Given this list of marker genes Slc23a2, Cadm3, Rab31, Strbp, Pex5, Sdhaf4, Maml2, Tdrd3 (tudor domain containing 3), Slc6a15, Wfdc12, Klf15, Araf, Foxf1, Egr3, Ccdc62, Dgkq, Acvr1, Zmym5, Prr3, Soat1, Dact1, Pard3 (par-3 family cell polarity regulator), Pik3r1, Sytl4, Klc1, Gli3, Prkaa2, Atp1b3, Rnf6, Kdm7a, Cntln, Epg5, Adat2, Mbnl3, Fut9, Cacna2d2, Arid2, Nckap1, Lrp2bp, Adamts20, Bcl9, Ssh2, Bcl6, Dlgap4, Tbx5, Nr2c2, Cdk6, Diaph2, Nif3l1, Tns3, Trip12, Il22ra1, Rabgap1, Suclg1, Rnf217, Ugt2b35, Rnf19b, Snrk, Zfp711, Erg28, Slc16a10, Slc25a27, Nufip2, Zfp811, Ebf2, Srgap2, Slc15a1, Zfp839, Or7d10, Cep70, Dhx40, Rab1a, Gpr4 (NCBI Gene Id 319197), Lmx1a, Eri1, Denr, Slf2, Epha4, Vapa, Tmem178b, Pfkfb2, Gabrb2, Efemp1, Ccna2, Poglut1, Adam2, Herc2, Ndufs2, Zdbf2, Phf21a, Rasgrp1, Ankrd44, Nemp2, Wdr43, Ptbp2, Prkaa1, Mapre1, Erc1, Klf6, Ubr5, Mgat4c, Creb1, Gnpat, Orc3, Lhfpl4, Tmeff2, Nfe2l3, Atxn1, Ranbp2, Ccnc, Qki, Xrcc4, Clec2g, Zfp1008, Siah1a, Kcnh5 (potassium voltage-gated channel, subfamily H (eag-related), member 5), Yme1l1, Grb2, Slc39a2 (solute carrier family 39 (zinc transporter), member 2), Pou2f1, Pappa, Inpp4b, Ccdc169, Mapk1ip1l, Macf1, Cdc73, Daam1, Dhx36, Amacr, Saa1, Trp53inp2 (transformation related protein 53 inducible nuclear protein 2), Olig2, Fbxo45, Get1, Msrb3, Nr1d2, Kdm2a, Xrn2, Arhgap11a, Plag1, Serpinb1b, Tmem254, Zswim5, 9530068E07Rik, Saa2, Mgam, Cxcl5, Pcdh18, Slc4a7, Tent4b, Dock1, B3gnt2 (NCBI Gene Id 85024), Radx, Col25a1, Psip1, Zdhhc21, Rpap2, A630001G21Rik, Srsf1, Slc10a6, Tgs1, Manea, Tent5a, Cpne8, Tnpo1, Cntn3 (contactin 3), Irs4, Ran, Abi1, Carmil1, Slc5a3, Rnf216, Parg, Rnf152, Dph3, Adamts9, Ino80d, Sgcd, Bpifc, Fam76b, Apc, Ptprb, Vsx2, Klrb1c, Kit, Snx30, Zfp934, Zfp808, Gucy1b1, Htr2b, Synpo2, Ash1l, Hlf, Cdk12, Rmnd5a, Ptprk, Erp44, Arhgap12, Lsm8, Elf1, Dsc3, Pde10a, Kif27, Gpr50, Adcy9 (NCBI Gene Id 28001), Fryl, Brd8, Gm5141, Tanc1, A130010J15Rik, 4930568D16Rik, Pafah1b1, Cep350, Dnajc19, Nup93, Ahctf1, Raph1, Usp2, Psd3 (NCBI Gene Id 80295), 2010106E10Rik, Edil3, Dnajb4, 1700028K03Rik, Plpp1, Gpkow, G3bp2, Pik3ca, Pcdh10, Fam120a, Nfxl1, Zfp281, Oxa1l, Glod4, Fhip2a, Gsk3b, Herc6, Zfp185, Runx1t1, Slitrk5, Usp27x, Foxa1, Ube2d2b (ubiquitin-conjugating enzyme E2D 2B), Adamts6, Adcyap1, Jag2, Nrep, Mcf2l (NCBI Gene Id 338499), Fam53c (NCBI Gene Id 66306), Elavl4, Tnrc6b (NCBI Gene Id 72625), Ssbp2, Ube2k, Cdc7, Kifc1, Zfp882, Chmp1b2, Ncam2, Ss18l1, Pigc, Tc2n, Csrnp3, Commd2, Grik2, Sema4b, Pde3a, Zfp706, Iapp, Rnf139, Sdcbp, Rab6b, Wnk3, Nwd2, Tram1l1, Dip2b, Rsbn1l, Hhip, Slc12a2, Rora, Mettl9 (NCBI Gene Id 99504), Csnk1d, Pcdh11x, Crh, Mat2b, Donson, Pid1, Anxa10, Rai1, Tiam1, Gm4791, Sec22a, Timm29 (translocase of inner mitochondrial membrane 29), Ptpmt1, Chd5, Dennd5b, 2310022A10Rik, Fam204a, Zfp236, Shb, Dpysl2, Ms4a6d, Hs6st2, Casz1, Klhl2, Mms22l, Pcsk2, Ptbp3, Abca14, Pigl, Slc8a1, Akap10, Sub1, Sox5, Kif5b, Sel1l, Kdm5c, Dcx, Mcam, Ubxn7, Krit1, Ogfrl1, Fermt2, Wdr59, Wt1, Zeb1, Fam171b, Taf4b, Ids, Ppm1d, Ptbp1, Top1, Mettl27, Ptchd4, Fam184a, Oas3, Gripap1, Lonrf1, Lmbr1, Unc5c, Fbxl17, Mrpl39, Vav3, here is a description of the gene set: species: Mus musculus from publication Chen Y, Wang X (PMID 31504780) Genes predicted to be targets of miRBase v22 microRNA mmu_miR_466i_3p in miRDB v6.0 with MirTarget v4 prediction scores > 80 (high confidence targets). Mouse Gene Set: MIR_466I_3P